Given this list of marker genes TDRD6, EIF4EBP2, HOOK3, UBE2Z, TTN, CCR3, OAS1, IQCK, DNPEP, F13A1, TRRAP, MON1B, PTK6 (NCBI Gene Id 5753), PDYN, WAC, MAPK10, SUV39H1, RLF, METTL21A (NCBI Gene Id 151194), CLN6, ASB6, NOL4L, SLC43A2, RORB, KCNJ1, NPAP1, GANC, PPM1B, RNF41, PPP1R42, ANGPT2, DCAF7, POP1, ITPR1, MTMR4, TMEM106A, LBH, TMBIM4, SNRPA, SOS1, PHRF1, SOX5, FBXO33, FAM53A, CWC15, BOK, CHIC1, RAF1, here is a description of the gene set: from publication Chen Y, Wang X (PMID 31504780) Human Gene Set: MIR764 Genes predicted to be targets of miRBase v22 microRNA hsa-miR-764 in miRDB v6.0 with MirTarget v4 prediction scores > 80 (high confidence targets). species: Homo sapiens